Given this list of marker genes TAMALIN, CAPG, TMEM71, EEIG2, ITGB3, IFNAR1 (interferon alpha and beta receptor subunit 1), SPACA9, ASS1, QPCT, MAPKAPK3, KLRD1, DYRK2, TNFRSF25 (NCBI Gene Id 8718), RAE1, FCGRT, CD96, ACSBG1, CCR2, ADD1, OTUD5, IMP3, RIOX2, SLFN5, PHYHD1, FRMD6, PRDX6, SHE, SLC17A9, TRAF3IP3, IFIT1, ITGB7, IL2RA, GOLM1, IZUMO4, SHD, TPST2, LAIR1, NDOR1, ADCY6, B4GALNT1, IRAK3, RPL4, MRPS5, SERPINI1, IL18, ATP1B3, KLF2, MYO1G, ADAM8, PLAC8, GALNT10, C21orf91, IL7R, SFN, RHOBTB2, HBEGF, STX1A, RGS14, RRAS2, USP48, MED7, AOPEP, PIK3R1, ATP8B4, APBB1IP, L1CAM, ZNF652, DENND5A, CABCOCO1, TMEM64, RCBTB2, SYTL2, DIPK1A, ITGA6, ARHGEF18, CD226, NDRG1, SURF2, DOCK10, DGLUCY, PGLYRP2, RBM38 (RNA binding motif protein 38), ARHGAP9, PEX11G, CFLAR, RRAD, SLC29A2, AKT3, LRRC8A, CD5, SFR1, SIKE1, SOCS2, ARMC7, STMN2, MATN2, NKG7, BST2, NHSL2, SIDT1, SHARPIN, SBK1, NUPR1, LRRC75B, SGMS1, SIT1, SPON1, CISH, FXYD7, IRF4, GGT1, CORO2A, ARMC10, ITGA4, PPM1J, ST8SIA6, GCOM1, ANXA1, S1PR4, SH3BP1, TXNIP, QTRT1, TKTL1, PPP1R18, PLA2G10, DUSP22, S1PR1, HVCN1, UBXN11, BEND6, RASGRP2, TMPRSS13, ADGRG3, ZPR1, RAPGEF6, ACP5, IGFBP4, ORAI2, RAP1GAP2, GBA2, RCN3, FAM78A, LRP4, TES, TENT5A, MX2, GPR34, STK10, USP3, ADGRE5, ARV1, KIF1B, SLC66A2, FOSL2, RELL2, ZNF274, ENTPD1, RXYLT1, LFNG, IKZF4, MTSS1, PIK3R5, FLT3LG, GRAP, NEB, HOPX, OSM, LMNA, STK38, GZMB, TNFSF4, DPH5, CACNB3, HID1, LBP, CPM, PDLIM4, RASA3, FLOT1, KLRK1, DDX19B, ADPGK, CRY1, ARHGEF1, NCF1, SYTL1, TECPR1, UST, ST3GAL6, IFITM3, FAM53B, PITPNC1, DCTN6, NOD1 (nucleotide binding oligomerization domain containing 1), HAAO, TBX21, PDE8A, TACC2, IFITM2, TDRP, here is a description of the gene set: species: Homo sapiens from publication Szatmari I, Pap A, Rühl R, Ma JX, Illarionov PA, Besra GS, Rajnavolgyi E, Dezso B, Nagy L (PMID 16982809) Genes down-regulated in monocyte-derived dendritic cells: AM580 versus rosiglitazone and AM580. Our data indicated that activation of the PPARg nuclear receptor induces a retinoid response in human dendritic cells. In order to assess the contribution of retinoid signaling to the PPARg response we decided to use a combination of pharmacological activators and inhibitors of these pathways. Cells were treated with the synthetic PPARg ligand rosiglitazone (RSG), or with RSG along with the RARa antagonist (AGN193109) to block RARa mediated gene expression, or the RARa specific agonists (AM580) alone. This design allows one to determine if retinoid signaling is a downstream event of PPARg activation and what portion of PPARg regulated genes are regulated via induced retinoid signaling. Human Gene Set: GSE5679_RARA_AGONIST_AM580_VS_AM580_AND_ROSIGLITAZONE_TREATED_DC_DN